The following is a description of a gene set: Human Gene Set: GSE27786_CD4_TCELL_VS_MONO_MAC_UP Each fraction of mouse hematopoietic cells was purified by cell sorting from bone marrow of 8-week-old C57BL/6 mice, and its gene expression was analyzed. studied in species Homo sapiens Genes up-regulated in comparison of CD4 T cells versus monocyte macrophages. from publication Konuma T, Nakamura S, Miyagi S, Negishi M, Chiba T, Oguro H, Yuan J, Mochizuki-Kashio M, Ichikawa H, Miyoshi H, Vidal M, Iwama A (PMID 21540074), and this is the list of marker genes: RBM4, EBP, RAB10, KCTD2, LRWD1, TNFAIP8L1, MED1, SF3A3, ARFRP1, ENSG00000267882, SMC4, MTAP, IL12RB1, NEURL4, MYO1E, SNHG6, ERAP1, RING1, SETX, BRD2, KCNQ1OT1, CTCF, KLF3, MYEF2, CNR1, DYNLL2, PSMA3, ZXDB, ABL2, PHF20 (NCBI Gene Id 80330), DCUN1D4, STK17B, IRF4, DDX39B, STC1, FAM120C, MANF, TIMM10, CDK13, JPT1, HES6, SOCS7, KBTBD2, SPATA6, AGO1, TXNL1, KCNMB4, LNPEP, FAM8A1 (NCBI Gene Id 51439), SMAD4, SAP30L, NFATC2, RCL1, PPP2R2A, EARS2, NSUN2, BTG3, MAP2K7, MTARC2, QNG1, GNPDA2, SOX3, TOMM7, BRWD1, TMIGD1, ARPC5L, KIAA0753, RAB3IP, RINT1, ZNF566, DOK2, DCAF11, ALKBH7, NFYC, FAM174C, PIK3R1, RBM22, SUCO, MAK16, CREBRF, HNRNPA0, HSD11B2, ARIH2, RPUSD4, TAP1, CEP95, GPRASP3, SMG1, FAM13B, ESCO1, GSK3B, SQSTM1, UBQLN1, MEPCE, VPS16, ANAPC16, RAB40C, MFSD3, ARGLU1, HTATSF1, AZI2, ZNF322, CLUAP1, TAF1C, CYSLTR2, RPS6KA3, STK32C, DNAJA4, KCNA7, RPL32, NAE1, PARP14, SNRNP25, MACROH2A1, UBXN4, ADI1, ACYP2, ALKBH5, PTGES3, RPL22L1, SLC7A6, TMEM70, PHTF2, PRPF19, ZNF292, IGBP1, ATF7IP, CPLANE1, CES3, GCDH, POLR2C, ADH5, SLC35D1 (NCBI Gene Id 23169), NKRF, COMMD7, SET, ZC3H14, COX11, TFAM, SLC52A2, RBMS2, GTF3C6, GLB1 (galactosidase beta 1), FLYWCH1, NHP2, ZC3H13, OSBPL5, HNRNPA1, CYP2D6, CDC5L, TAF4B, EIF3A, ATPAF1, NSDHL, TTC39B, CARD6, EI24, ANGPTL4, RIPOR1, IL21R, TRIM47, DENR, CCT8, SKP1, ABCB9, SLC20A1, COX14, COX18, ARF6, TRIM59, TCHP, IMMP1L, UBE3A, CLK3, CRTAM, ENSA, NELFB, NUP214, UNC45A, ARK2C, CCT6A, POU5F2, ZNF622, POLR1H, TEX10, RAD1, ZNF707, ANKRD44, CHD6, HARS1, SOCS3, FTO, PRKAR1A, HARBI1, IRF1, ALDOC, ZBTB20, PSMD12, TAF3, APOBEC2